The following is a description of a gene set: Genes down-regulated in comparison of untreated CD4 T cells at 0 h versus the untreated cells at 2 h. from publication Elo LL, Järvenpää H, Tuomela S, Raghav S, Ahlfors H, Laurila K, Gupta B, Lund RJ, Tahvanainen J, Hawkins RD, Oresic M, Lähdesmäki H, Rasool O, Rao KV, Aittokallio T, Lahesmaa R (PMID 20620947) Human Gene Set: GSE17974_0H_VS_2H_IN_VITRO_ACT_CD4_TCELL_DN The aim of this dataset was to study in detail the transcription kinetics initiated by cytokine IL-4 in early differentiation of Th2 cells. species: Homo sapiens, and this is the list of marker genes: ST8SIA4, LEO1, MAGOHB, C6orf120, DNAJB6, MARS2, IRF4, MED7, CCNH, NIFK, C11orf24, CAAP1, URB1, SIPA1L1 (NCBI Gene Id 283567), SLC7A1, TMEM88, EGR1, FAM83G, TNF, ZNF684, SDF2, MOB3C, C2orf42, S1PR3, EGR3, CIPC, NEMP1, SPAG1, MPLKIP, ARG2, TXLNA, NR4A1, DUSP14, GLB1, SLC25A19, GNPNAT1, WDR3, NCBP1, PLEKHA3, HCP5, KANSL1L, GLRX3, TRDMT1, CEP19, DSE, SPRY1, CEP83, MIR3667HG, ZNF583, CC2D1B, CTNNAL1, FADD, SLC17A5, ZNF215, TIMM8A, PIGM, TOB2, SNX16, C1orf56, MIR155HG, ZFP3 (ZFP3 zinc finger protein), CTSL, TMEM165, BET1, DNAJC17, ELK3, METTL13, BCL2A1 (NCBI Gene Id 597), KCTD21, MTO1, ZNF140, GFOD1, GOT1, HSF5, VMP1 (vacuole membrane protein 1), RBBP8, ZNF879, MTHFD2, ZNF235 (zinc finger protein 235), GEMIN6, CTTN, NOG, ALKBH8, ZFP69B, FASLG, CRNDE, APOBEC1, GHRLOS, COPB2, TUBD1, KTN1, PKNOX1, ADO, MLYCD, COX17, ARHGEF2, EIF2B2, UMPS, DLAT, MIR3142HG, SERPINE2, LYAR, ZNF234, VASP, NUP42, ORAI1, MED31, PPM1D, CAMSAP2, KLF10, NUDCD1, MYB, OSBPL11, DESI1, DCUN1D3, PHLDA1, RANBP1, LTA, TTI2, ZNF276, CPEB2, MRPL35, CDK4, MED21, NAPEPLD, PNO1, PPP1R10, BSPRY, LYST, EMP1, SH3PXD2A, EXOSC3, UTP14C, AIRIM, FYCO1, TUBE1, PPIL1, C14orf119, CD200, EXOSC4, PHF23, GRAMD4, LYPLA2, ZBTB8A, PKIA, ARMT1, NUBP1, TEX30, TNFAIP6, ERLIN1, RAB39B, EVI2A, MTERF3, GRAPL, ZC3H10, NAB1, TMEM223, LAMP3, IMP3, GET1, CHSY1, CLDN1, OSBPL3, SERTAD1, BRIX1, MTNAP1, ABAT, PLPP5, SRFBP1, ZSWIM6, C1GALT1C1, TIMM13, ZBTB42, LIF, TBL2, EEIG2, PTPN22, GON7, COA4, LINC01128, EGR2, RNF168 (ring finger protein 168), FBXO22, LYSET, NT5E, GNL2, POLR3D, RLN1 (relaxin 1), CRNKL1, CD58, TRMT6, PUS3, RAB27A, STX6, CISH, ZNF416, GLMN, RIF1, CCL20